Given this list of marker genes JUN, LDLR, LAMC2, ETS2, MCL1, ATF3, BMP2, INHBA, IER2, IER3, EREG, GEM, ZFP36, IFNGR2, CXCL3, PLK2, IL6, TNFAIP3, DUSP8, CD83, JUNB, BIRC3, CXCL1, CSF2, ZFP36L2, NFKB2, KLF6, DUSP10, NFKBIA (NCBI Gene Id 4792), EGR1, FOS, PTX3, BHLHE40, ADAMTS9, TNFAIP2, CEBPD, EGR2, BTG1, CCL20, REL, FJX1, DUSP5, SDC4, KLF10, TNFRSF10B, CD44, ICAM1, DUSP1, NUAK2, LIF, CXCL8, IRF1, IL11, KDM6A, BTG3, EPHA2, CCNL1, CXCL2, PLAU, NKX3-1, BIRC2, KLRC1, IER5, here is a description of the gene set: p38 mitogen-activated protein kinase (MAPK) is rapidly activated by stresses and is believed to play an important role in the stress response. While Chk1 is known to mediate G(2) DNA damage checkpoint control, p38 was also reported to have an essential function in this checkpoint control. Here, we have investigated further the roles of p38 and Chk1 in the G(2) DNA damage checkpoint in cancer cells. We find that although p38 activation is strongly induced by DNA damage, its activity is not required for the G(2) DNA damage checkpoint. In contrast, Chk1 kinase is responsible for the execution of G(2) DNA damage checkpoint control in p53-deficient cells. The inhibition of p38 activity has no effect on Chk1 activation and gamma-H2AX expression. Global gene expression profiling of cancer cells in response to tumor necrosis factor alpha (TNF-alpha) revealed that p38 plays a strong prosurvival role through the coordinated downregulation of proapoptotic genes and upregulation of prosurvival genes. We show that the inhibition of p38 activity during G(2) DNA damage checkpoint arrest triggers apoptosis in a p53-independent manner with a concurrent decrease in the level of Bcl2 family proteins. Our results suggest that although p38 MAPK is not required for the G(2) DNA damage checkpoint function, it plays an important prosurvival role during the G(2) DNA damage checkpoint response through the upregulation of the Bcl2 family proteins. from publication Phong MS, Van Horn RD, Li S, Tucker-Kellogg G, Surana U, Ye XS (PMID 20516219) studied in species Homo sapiens Genes up-regulated in Calu-6 cells (lung cancer) at 1 h time point after TNF treatment. Human Gene Set: PHONG_TNF_TARGETS_UP